The following is a description of a gene set: Human Gene Set: WP_NEPHROTIC_SYNDROME Nephrotic syndrome species: Homo sapiens, and this is the list of marker genes: COL4A5, LMX1B, ZMPSTE24, PLCE1, GPC5, WDR73, PAX2, WT1, COQ2, COL4A4, NPHS1, ITGB4, SYNPO, CTLA4, ARHGAP24, SMARCAL1, COL4A3, E2F3, CYP11B2, ARHGDIA, LMNA, CD151, APOL1, INF2, TRPC6, MYH9, MYO1E, CUBN, PMM2, PDSS2, ANLN, YARS1, ACTN4, PTPRO, PODXL, TTC21B (NCBI Gene Id 79809), CD2AP, SCARB2, NPHS2, COQ6, ALG1, EMP2, LAMB2, ITGA3, COQ8B